Given this list of marker genes MIR483, MIR92A1, PNRC2, SHFL, GSPT1, NAV3, BBS2, INPP5E, MIR384, MIR296, RCOR1, MIR302C, H3-3B, MAPK14, MYC, PLD6 (NCBI Gene Id 201164), TRAF3IP2, ARG1, DEFB114, MIR96, MIR613, MIR148B, SMARCA1, RBM33, MIR661, ZNF808, MIR1208, EIF4EBP2, PATL1, TDRKH, EIF4A3, MIR1251, MIR644A, A1CF, MIR4500, IRAK3, TGFB2, PIWIL1, ESR1, TENT5C, PHF2, KDM5A, CACNA2D1-AS1, DCPS, ARRB1, GZMB, CHMP1A, MIR196A1, H2AB2, TESK1, LBP, MIR320D1, MIR573, H2AC11, MIR133A2, MIR891B, MIR188, MIR33A, RNPS1, MIR526B, MIR218-1, MIR504 (NCBI Gene Id 574507), DHFR, MIR1207, MIR200B, HSPA1A, FXR2 (NCBI Gene Id 9513), MIR22, MIRLET7F2, MIR132, BAP1, MIR938, MEG3, CITED2, DAPK3, NDFIP1, KDR, IL23R (interleukin 23 receptor), MIR331, AKT1, MIR922, RPS6KA4, DHX9, MAGEA3, GPR174, PIAS4 (NCBI Gene Id 51675), SMAD3, HAVCR2, MIR27B, CRYAA, MIR203A, MIR3180-5, ATP2B1, MIR582, ABCD2, CPEB3, MSX1 (msh homeobox 1), CD28, RGS2, PNPT1, TWSG1, MIR449B, WNT4, CNOT3, MIR9-1, KPNA7, MIR652, OTUD6B, MIR486-2, MALAT1, TNRC6B, MIR575, MIR802, MIR626, EZR, NKX3-1, ACIN1, U2AF2, YAP1, UPF3B, TREM2, H1-2, FMR1, TNFSF4, CAPRIN2, MIR557, MIR135A2, MTA1, GRB7, MIR526A2, RAC1, MIR191, SIGLEC1, MIR586, IGF2BP1, PARP10, CXCL8, PHF1, YTHDF3, MIR766, SKIC8, CTR9, LBR, CAPRIN1, MIR550A3, CD2AP, TENT2, DIP2A, APP, SRSF6, EXD1, PAN3, EXOSC8, MIR215, MAP3K20, SMCR8, MIR505, UPF3A, ITCH, HDAC9, MIR1197, SRGN, MIR144, CHRNA7, SKIC2, SIRT2, CNOT9, MIR514A1, UCN, EPHB2, MIR655, MIR367, PRKCA, MIR7-2, HAND2 (NCBI Gene Id 9464), MAP3K7, CD274, MIR152, TIAL1, EED, AJUBA, ROCK2, H2AB3, CD24, MIR653, TSPO, NOTCH2, MIR432, MIR99A, MIR141, ANAPC2, CARD17P, MIR145, ZC3H7A, MIR106A, MYCN, MIR518D, MIR500B, PRNP (NCBI Gene Id 96713), MIR10A, MACROH2A2, UNK (unk zinc finger), ENG (endoglin), PURB, IL36RN, MIR551A, PPP2CB, MIR155, RIPK1, LSM2, EIF6, MIR595, MIR34A, MIR29A, MIR2355, H2AC15, MIR1224, PRKCH, MIR574, MIR572, MIR494 (NCBI Gene Id 574452), KAT5, PIAS3, LRP1, SESN2, MIR485, ITGB8, CD84, MIR29B1, DHX34, CLP1, XRN2, MIR944 (microRNA 944), HMOX1, TTC5, DXO, MBD3L5, C19orf84, MIR323B, DHX58, EPHA2, WNT11, DDX17, H2AC6 (NCBI Gene Id 8334), PCIF1, MIR520A, SMAD7, NLRP12, MIR320B2, MIR548D2, PLA2G10, OTUD5, FAM76B, MIR363, MPHOSPH8, OPRD1, FASTKD3, ENC1, MIR126, ABCD1, MIR638, NICOL1, JAK3, NUDT16, INHA, NUDT16L1, RNH1 (NCBI Gene Id 6050), SMG1, CCR7, PRG3, SRSF9, TMBIM6, KLHL22, ZFP36L1, MIR103A2, APOBEC3A, GPNMB (NCBI Gene Id 10457), MIR1306, MAPT-AS1, TMEM98, MIR193B, MIR498, PYDC2, RBL1, CD33, MIR3065, MOV10L1, RBMS3, MIR600, IFNB1, MIR760, SENP1, MAEL, BOLL (boule homolog, RNA binding protein), TCEAL1, JAK2, MIR1908, SERPINE2, RBM4, EZH2, PABPN1L, MIR103B2, CPEB1, MIR320E, H2AC13, MIR3661, CRYAB, MIR133A1, IGF2BP3, MIR660, TFAP4, SIRT4, MAP2K1, PTGER4, MIR592, TNRC6A (trinucleotide repeat containing adaptor 6A), MIR193A, SFRP2, RNF216, SIN3A, OAS1, MIR28, PCBP4, PPM1B, SOX11, MIR26A2, IREB2 (iron responsive element binding protein 2), MIR551B, MIR1296, DDRGK1, HOXA11-AS, CX3CR1, ERP29, MIR197, TERT, PLEKHN1, SNX12, MIR544A, OVOL2, MIR30B, MIR181A1, XRN1, MIR9-3, MIR299, MIR519B, MIR569, CALCR (calcitonin receptor), DAZ2, MIR424, SIRPA, CILP, MIR320A, SMO, DNMT3L, SYNCRIP, MIR454, MIR376C, AGT (angiotensinogen), H2AC4, MIR17HG, VIP, MIR519D, APOBEC1, MIR4516, MIR1265, MIR501, E2F1, MIR433, ANXA1, MIR543, MIR609, PGLYRP3, MIR3173, MIR448, RC3H1, TRAF3IP1, RGCC, MIR488, STOX1, POU3F2, MIR375, MIR9-2HG, MIR525, MIR3074, CSDE1, MIR548H3, MIR611 (NCBI Gene Id 693196), RBMX, PML, MIR3180-3, DIS3L2, SFRP1, MBD3L1 (NCBI Gene Id 85509), PDCD10, PATL2, GATA5, MIR376B, INS, MIR1237, RELB, HDAC6, HNRNPU, MRTO4, GBP1, PRKAA1, PPP1R11, BMI1, BPI, MAPKAPK2, SSB, IL23A, JARID2, HNRNPA0, PPARG, MIR892B, HHEX, MIR9-2, CD200R1, MIR1183, MIR631, CTIF, IL1RL1, CNOT6, HDAC8, RBM15B (RNA binding motif protein 15B), ING2, MIR521-2, H2AZ1, MIR519A1, MIR1912, SIRT7, MIR550A1, PABPC1, SMARCA5 (SWI/SNF related, matrix associated, actin dependent regulator of chromatin, subfamily a, member 5), H2AC21, MIR137HG, MIR549A, PARP15, ELANE, NRXN1, MIR147B, MAPKBP1, CNOT2, EPM2A, NR0B2, TOB1, MIR21, MIR103A1, MIR519E, SRSF4, MIRLET7A2, SMAD1, FLOT2, FERMT1, VEGFB, MIR767, TAF1, MIRLET7B, MIR382, TICAM2, MIR1298, ZAR1L, SFMBT2, HEY2, HOMER3, MIR31, MIR302A, N4BP1 (NCBI Gene Id 9683), MIR219A1, APOE, CREBZF, MIR329-2, USP7, LSM7, TUT1, MIR676, UBR5, EXOSC7, SERPINF1, PUS7, SPACA6-AS1, VEGFA, ATG9A, EXOSC9, EIF3E, TRIB2 (NCBI Gene Id 28951), PARN, MIR137, DDX3Y, MIR520B, SMARCA4, MIR103B1, FUS, TNFRSF21, NLRP7, NUDT12, SRSF3, NDFIP2, MIR885, PARP16, ROCK1, EIF2AK3, TENT4A, APPL2, ZFP36, MIR548A3, MIR523, RPS13, MIR1302-2, MIR577, BCDIN3D, HLA-F, NPTN, MIR506, MIR16-2, NMBR, NORAD (NCBI Gene Id 647979), MIR199A2, MIR412, SPTY2D1, SPOCD1, PARP9, MIR1226, MUL1, CHEK1, HDAC7, ZC3H10, MIR518F, ACO1, MIR1185-1, MIR651, ZNF540, ZHX2, TYROBP, HELLS, NTS, RNASEL, EPC1, MIR1302-4, NFKBIL1, TIRAP, NANOS1, FGA, IL10, CD83, PDCD4, GPAT2, MIR1283-2, UPK3B, SERPINB1, OIP5-AS1, MIR200A, F2, STC2, UPF2, KDM4A, ANGPT1 (angiopoietin 1), MAGOHB, DNMT3A, WT1, SMYD5, APOBEC3F, MIR502, APEX1, MIR3180-2, NPLOC4, HOMER2, C1QBP, LAG3, PLAT, SARS1, ACP4, MIR23A, RBM8A, PDCD1LG2, GAS6, MIR3619, BAK1, CPEB2, TEX15, METTL16, MIR5588, CX3CL1, MIR450A2, MIR521-1, IFI16, MIR374B, MIR497, TUSC2, PRKRA, ADAM10, MIR26A1, ORM1, MIR1277, DICER1, SLC35C2, UHRF1, PCGF3, LGALS9B, MIR20B, L3MBTL1, POLR2G, MIR125A, MORC1, SLIT3, FOXP3, LIMD1, MIR548X2, MIR920, MIRLET7A3, HNRNPK, RBM10, MAPT, MIR451B, CBX3, RPS6KA5, RABGEF1, CD200, MIR361, BMPR1A, MIR219A2 (microRNA 219a-2), FOCAD, GDNF, MIR518C, CNOT8, C1QTNF3, SFSWAP, MIR346, MIR23B, EHMT2, CNOT11, MIR650 (NCBI Gene Id 723778), FCRL3, MIR665, PDE12, ZNF281, MIR4691, RLF, LSM1, HMGB2, MIR615, F2RL1, MIR526A1, MIR601, USP17L2, MIR27A, H2AC1, SLC7A5, MIR410, MIR515-1, GSPT2, MIR496, EIF2AK4, HOTTIP, HFE, LRP3, CREB3L1, GBA1, TBX21, MIR125B1, LARP1, NLRP2B, C8orf88, MIR934, TP53INP1, TDRD9, POMC, GATA2, FXR1, ANXA7, MIR107, MIR34B, DDX4, FGF2, MIR370, CUL3, HIF1A, SLC24A3, MIR649, PTPN6, MIR621, MIR379, MIR184, MIR371A, EIF4EBP1, CDK1, KLF2, PTPN22, LGMN, MIR1227, MIR517B, SOCS5, MIR744, HELZ2, REST, DAPL1, KHSRP, MIR558, HELZ, SPI1, GPATCH3, ZNF598 (NCBI Gene Id 90850), MIR124-2, MIR940, RLIM, PRKCD, IGF1, INPP5D, DAZ1, MIR105-1, EHMT1, PYCARD, MIR323A, H2AB1, BANF1, MIR550A2, MIR875, CALR, TASOR, MIR548P, SRRT, RBM38, PIWIL4, NRDE2, DNAJC3, MIR520E, MIR6086, DAZ4, MIR548AZ, PRKAA2, MIR338, MIR520D, MIR548H2 (microRNA 548h-2), ATOH8, MIR516A2, RARA, TASOR2, CDYL, DAZ3, MIR181D, EPX, PHF19, MIR124-1, MIR30C1, MIR136, MIR411, SAMD7, MIR4686, MIR1262, PTPN11 (protein tyrosine phosphatase non-receptor type 11, NCBI Gene Id 84990), GSTP1, CUEDC2, MIR146A, MIR302E, DLL4, VIM, BAZ2A, MTPAP, FYN, IL12B, MIR30D, MIR935, MIR133B, DIS3L, CTSZ, TRIM28, MIR133A1HG, RNF139, MIR298, PGR, MIR153-1, TLR4, L3MBTL2, XPO5, MIR30E (microRNA 30e), MBD3, TSKU, TUT4, MIR146B, DIS3 (NCBI Gene Id 22894), ARRB2, MIR581, H1-0, MIR101-1, APOA1 (apolipoprotein A1), ACE, PNLDC1, RBM24 (RNA binding motif protein 24), SSC5D, PUM1, REL, MIR190B, ELOC, SMARCAD1, GHRL, MIR499B, ZNF91, MIR34C, CTCF, EIF2AK1, BEND3, OCLN, ALKBH3, ARB2A, MIR524, MIR101-2, MIR758, MIR499A, PRG2, ZNF93, MIR381, PRR5L, MIR663B, MIR548AA2, NOS2, MIR486-1, SELENOS, ACVR1B, WFS1, RPS3, BTN2A2, MIR92A2, MIR675, BCL3, MIR450A1, MIR520H (microRNA 520h), CDKN2B-AS1, MIR493, MIR580, DNMT1, ZC3H7B, LMNB1, ZBTB7B, ATF7IP, MIR205, RBL2, CNOT1, CD22, TNF, DND1, PLAG1, MIR541, PSG9, H2AJ, CSDC2, MIR628, HMGA2, PARP14, MIR182, ENDOU, H2AX, MIR340, IL37, WTIP, CSK, SOX9, SRP9, MIR633, LSM4, CNPY2, MIR194-1, TNFAIP3, ROBO1, LGR4, INHBA, MIR183, MALSU1, MIR548M, AXIN2, MIR326, MIR567, DDX56, FBXW7, PGLYRP2, ASB1, IL6R, OLFM1, FOXP1, MIR199A1, THRAP3, LSM5, TRIM71, MIR1180, MIR122, ATG12, MIR378A, ANG, MIR563, MIR206, CNOT7, H2AC7, ZFP36L2, N6AMT1, FASTKD1, YTHDC1, TLR6, MIR711, MIR576, SIRT6, STAT3, MIR330, MIR761, MIR668, SRSF12, RIF1, SPINK5, PAN2, MIR300, TNP1, MIR616, RNF125, TBK1, MIR455, PAIP2B, HDAC5, ZNF410, MRPL13, MIR769, MIR362, PKP1, KLF4, MIR487A, MIRLET7G, MIR134, ZC3H14, H2AC16, BAHD1, MIR29C, MIR1246, QKI, NANOS3, LL22NC03-63E9.3, GGNBP2, MIR657, LDLR, MIR516B2, PKP3, GBP7, MIR181C, CARD18, MIR129-2, MIR105-2, MIR639, MIR138-2, MIR554, MIR148A, EZH1, MIR1307, PARP3, MIRLET7D, MIR429, MIR92B, ZFAT-AS1, SMG6, MIR196B, METTL4, ANGEL2, MIR139, SUPV3L1, MIR608, ERBIN, GHSR, OTUD7B, CCDC3, RBM47, MIR636, PNRC1, MBD3L2, LSM6, MIR1253, PIWIL2 (NCBI Gene Id 55124), INHBB, MIR337 (NCBI Gene Id 442905), MIRLET7F1, MIR373, UHRF2, PYM1, MIR924, PTBP1, MIR149, EIF4EBP3, MIR643, MIR374A, TAF15, SUZ12, TIGIT, H2AP, RAN, IFRD2, MIR520F, IL13, DGCR8, TARBP2, BTG2 (NCBI Gene Id 7832), MIR365A (NCBI Gene Id 100126355), MIR216B, MIR383, NMI, MKKS, MIR942, FOXJ1, FFAR4, HDAC2, NEAT1, NOG, MIR564, MIR140, MIR3184, MIR369, MIR583, MIR527, MIR142, SRSF1, MIR891A, MIR490, H1-9P, ACVRL1, THBS1, RACK1, SMG5, MIR17, HDAC3, MSR1, NOTCH1, HGF, SUV39H1, FFAR1, MIR204, DGKQ, MIR1275, MIR516B1, MIR522, MIR518A2, SRSF10, MIR491, SMCHD1, HOXB-AS3 (HOXB cluster antisense RNA 3), MIR212, MIR662, TSNAX (translin associated factor X), MIR18A, DAP, LARP1B, MIR222, ERN1, PTRH2, MIR19A, MIR517C, FN1, MIR4286, MIR671, MIR214, MIR3148, DHX36, SERPINF2, MIR1181, NCL, MIR423, MIR873, BTBD18, RIDA, PPHLN1, IL1R2, WWP2, MIR217, CYFIP1, MIR765, RB1, MIR495 (NCBI Gene Id 574453), FBLN1, MIR409, PIWIL3, MIR425, MIR130B, PRKN, TFAP2C, GTSF1, BMP2, ZNF683, GSK3B, MIR301A, TRAF2, NANOS2, MIR34BHG, MIR186, CCR1, CPNE1, PICALM, NLRX1, NLRP3, PRKACA, MIR181B2, TRIM27, TP53, MIR130A, TNKS1BP1, CRYBA1, ZAR1, IFNG, CD3E, PC, EIF4E, MIR24-2, DROSHA, AGO3, MIR607, NLRP6, MIR1-2, CTNNB1 (catenin beta 1), TUSC8, MIR339, MIR517A, DCP1A, AFF2, ZCCHC7, MIR192, PLAU, HEYL, CMKLR1, RELA, CEACAM1, LEF1, FCGR2B, AXIN1, ILRUN, ARG2, FURIN, H2AC18, AXL, MIR422A, MIR301B, MIR1225, MIR1287, MIR15B, IKBKB, MIR194-2, MIR150 (microRNA 150), UFD1, MARK1, AGO4, FASTK, MIR377 (NCBI Gene Id 494326), APOBEC3B, PSEN1, MIR23AHG, ZNF445, LIN28B, FTO, TWIST1, MTF2, MIR520G, EXTL3, H2AZ2, SLC11A1, ZC3H12D, ID2, IL13RA2, CELF4, MAP2K5, PTPRC, IL20RB, PRKAR1A, MIR210, MIS18A, APOA2, FBXO24, IKBKE, MIR889, APLN, IL27RA, EXOSC6, EIF4ENIF1, MIR449C, EXOSC5, FBLL1, RNASEH2B, MC1R, MIR3591, EPHA4, H2AC12, ATRX, NFKBIA, PURA, PUM2, GPR18, SHMT1, MIR143 (microRNA 143), MIR663A, H3-3A, MIR99B, MIR147A (NCBI Gene Id 406939), METTL3, ID3, MIR1302-5, HAT1, TYMS, MIR584, SAMD4A, IGF2BP2 (NCBI Gene Id 10644), MIR642A, MIR221, MIR451A (NCBI Gene Id 574411), ATG5, SPOUT1, MIR218-2, SETDB2, MIR342, NUP155, SUV39H2, TGFB1, AKAP8, METTL14, HNRNPAB, EDC4, CLDN5, MIR599, MIR625, TDRD6, MIR3142HG, CACNG7, MIR1827, TDRD12, PTPRS, ERI1, MIR770, GTPBP1, HNRNPA2B1, VHL, CARHSP1, MIR195, MIR624 (microRNA 624), DAPK1, SDR16C5, MIR604, TDRD1, RPS26, MIR181B1, TRIP12, PIK3CA, TDRD7, HENMT1, PARK7, MIR3677HG, ZBTB20, DCP2, SERPINE1, EXOSC10, GLG1, TENT5D (NCBI Gene Id 169966), MIR10B, DHFRP1, ZNF503, RBM46, MIR511, MBD3L2B, MIR125B2 (microRNA 125b-2), NBDY, PUS10, MIR503, MIR16-1, LARP4B, SFTPD, H2AC20 (H2A clustered histone 20), CYLD, MIR3909, UBR2, HRAS, MYADM, MIR640, BANK1, MIR1185-2, MACIR, MIR449A, AGO2, MIR939, HSPA1B, TEX19, MORC2, ACOD1 (aconitate decarboxylase 1), MIR335, KMT2D, NCBP1, MIR548D1, ADNP (activity dependent neuroprotector homeobox), MIR203B, SPEN, MIR202, CSNK2A1, DOT1L, SAP18, TIA1, EIF4G1, CLEC4A, HINFP, MOV10, GTPBP2, MIR196A2, SNIP1, CLDN19, MIR4632, RBX1, MEF2C, APOBEC3C, CNOT6L, PPP3CA, MIR550B1, EDC3, NR1H2, MIR593, ZC3HAV1, NCKAP1L, EXOSC3, TENT5A, MIR487B (NCBI Gene Id 664616), MIR632, CRH, DDIT3, FKBP6, ELAVL1, CD34, MBD1, TRUB1, LHX2, PAIP1, NOCT, MIR154, MIR124-3, PDGFB, SCX, PIBF1, SERBP1, LTF, MIR3529, MIR618, PCGF5, MIR1255B1 (NCBI Gene Id 100313806), CARD8, MIR520C, MIR548AJ2, MIR190A, MIR24-1, POLE3, SMG7, HLA-DRB1, MBD3L3, ZNF304 (zinc finger protein 304), MIR30A, PTENP1-AS, DLL1, VSIG4, MIR128-1, YY1, MIR509-1, MIR30C2, SMAD5, FASTKD5, AGO1, IL33, DAXX, HMGB1, DCP1B, CIZ1, MEIOC, CD36, MIR211, GIT1, MIR648, RNF128, CIDEA, CACTIN, LAPTM4B, NT5C3B, GIGYF2 (GRB10 interacting GYF protein 2), ILF3, ALKBH5, H2AL3, MIR562, TDRD5, CENPV (centromere protein V), BBS4, MIR588, NPM1, MIR219B, ZNFX1, MIR489, MIR320C2, PINK1, MIR329-1, OAS3, KAT8, MIR612, IGFBP5, DDX3X, MIR374C (NCBI Gene Id 100500807), EPRS1 (glutamyl-prolyl-tRNA synthetase 1), VPS35, YTHDF2, BTK, IL6, SH3GL2, NLRC3, GAS1, SCGB1A1, SECISBP2 (SECIS binding protein 2), HNRNPC, ATM, NMNAT2, MIR532, MIR877, MIR539, TNRC6C, MIR708, MIR25, H2AC25, MIR345, CLDN3, CPTP, MORC3, HDAC4, BRCA1, MIR29B2CHG, MIR518B, CASP3, CPEB4, TBRG4, DAZL, LILRB4, SHH, PPARA, MIR135B, RPL13A, ID1, LRRC32, MIR200C, IDO1, MIR135A1 (NCBI Gene Id 406925), TRAIP, SIRT1, SCRIB, IL4, PAIP2, CASC3, SPIN1, NCBP3, H2AC17, LILRA5, GAPDH, EIF2S1, MIR590, MIR548C, SKIC3, MIR208A, CRKL, AGER, MIR3179-2, TRAF5, RBM20 (RNA binding motif protein 20), MIR320B1, MIR187, IFNL1, MIR876, TRIM37, CELF1, MEFV, MIR519A2, APOBEC3G (NCBI Gene Id 80065), CNOT10, SYT11, KMT2A, MIR100, MIRLET7I, MIR98, MIR1178, EMILIN1, IFNA2, MIR492, ELAVL4, MAGOH, CARMN, MIR508, MIR26B, MIR542, TRIM6, CREB1, SRSF7, TARDBP, MIR936, ELOB, HOXA10-AS, BCL6, RESF1, NCBP2, MIR320C1, MIR33B, MIR1271, ASZ1, LIN28A, H2AC19, SMAD5-AS1, KAT2B, C5AR2, RRP8, MIR34AHG, CCNB1, MIR181A2, PYDC1, NDRG2, ZPBP2, MIR32, CBX5, RBM15, MIR550B2 (NCBI Gene Id 100500830), TIPARP, MIR18B, TGFB3, LSM14A, PRDM14 (PR/SET domain 14), MIR6869, MEX3D, MERTK, MIR3180-4, MIR93, DNM3OS, ARID5A, CHD4, DDX5, MIR1-1, PGLYRP1, SPINK7 (NCBI Gene Id 84651), CARD16, SLAMF1, TPR, MIR138-1, YBX1, MIR548H4, MIR208B, MIR223, MIR19B1, ETF1, PELO, ZMPSTE24, GATA6, CCN2, SCMH1, MIR372, CD46, GPER1 (NCBI Gene Id 2852), SMARCA2, ELF4, MIR7-1, LGALS9C, MIR376A2, MIR518E, RBM42, BAZ1A, EDN1 (NCBI Gene Id 1906), HDAC1, MIR320D2, XAF1, MIR302B, SND1, ERRFI1, LILRB1, H2AC8, CDK2, MIR224, MIR552, MIR216A, ADCY7, MYD88, BMP4, MIR656 (NCBI Gene Id 724026), MIF, XCL1, CDKN1A, BST2, MIR127, MIR589, MIR642B, LMNA, ZSWIM8, TENT5B, MIR500A, IL12A, TGIF1, EXOSC4, MIR516A1, HABP4 (NCBI Gene Id 22927), CBX1, ADIPOQ, SAMD4B, MBD2, PTH, MIR887, NFKB1, MIR7-3, LSM14B, STAU1, MIRLET7A1, MIR3120, MIR199B, MIR605, PAWR, MIR20A, CD96 (NCBI Gene Id 337949), TSN, MIR518A1, APLNR, NR1H4, YBX3, PRDM1, MIRLET7BHG, MIRLET7C (microRNA let-7c), APOBEC3H, EXOSC2, TTBK1, MIR198, ARB2BP, MIR185, NMB, FASTKD2, NBAS, DDX6, MIR484, MIR29B2, PABPC4, GATA3, TMF1, LILRA4, MECP2, MIR452, LMNB2, MIR450B, VSIR, ZFP92, HBS1L, LAPTM5, EIF2AK2, UPF1 (NCBI Gene Id 5976, UPF1 RNA helicase and ATPase), SLFN14, HES1, MIR129-1, ACP5, MIR659, YTHDF1, MIR1260B, ZNF148, MDM2, MIR578, FGF19, POU4F1, RC3H2, PTBP2, MIR106B, MIR597, MIR151A, ANXA4, ATP2B4, ABCC2, MBD3L4, LRIF1, AURKA, MIR874, TENT4B (terminal nucleotidyltransferase 4B), SMG9, XIST (X inactive specific transcript), CHAC1, MIR328, CNOT4, HNRNPD, IQGAP3, CHID1, TLE5 (NCBI Gene Id 166), MIR654, LGALS9, TUT7, MIR1249, ZFPM1, MIR302D, MIR324, CCL3, LINC-ROR, SLC2A10, PLA2G3 (NCBI Gene Id 50487), MIR519C, MIR15A, TLR8, RAD21, DYRK1A, PHF8, SMG8, CIRBP, LRRK2, PCID2, FGFR1, PARTICL, INPPL1, MIR937, ADAR, MLH1, IRGM, PPM1D, APOD, PTBP3, SETDB1 (NCBI Gene Id 9869), MIR19B2, MIR764, CR1, MIR1283-1, MIR553, SMAD2, MIRLET7E, SIGIRR, ZC3H12A, MIR155HG, MIR556, HSF1, ATF4, EIF4E2, PRMT5, MACROH2A1, here is a description of the gene set: Any process that decreases the frequency, rate or extent of gene expression. Gene expression is the process in which a gene's coding sequence is converted into a mature gene product (protein or RNA). studied in species Homo sapiens Human Gene Set: GOBP_NEGATIVE_REGULATION_OF_GENE_EXPRESSION